Given this list of marker genes CDH1, APC2, TCF7L2, CDH2, DSG1, APC, CTNNA1, DSC3, LEF1, PTPRJ, PTPRK, PTPRT, here is a description of the gene set: species: Homo sapiens Human Gene Set: GOMF_GAMMA_CATENIN_BINDING Binding to catenin complex gamma subunit.